The following is a description of a gene set: studied in species Homo sapiens from publication Sengupta S, den Boon JA, Chen IH, Newton MA, Dahl DB, Chen M, Cheng YJ, Westra WH, Chen CJ, Hildesheim A, Sugden B, Ahlquist P (PMID 16912175) Genes whose reduced expression in nasopharyngeal carinoma (NPC) correlated most with the increased expression of EBNA1, a latent gene of Epstein-Barr virus (EBV). Human Gene Set: SENGUPTA_EBNA1_ANTICORRELATED To identify the molecular mechanisms by which EBV-associated epithelial cancers are maintained, we measured the expression of essentially all human genes and all latent EBV genes in a collection of 31 laser-captured, microdissected nasopharyngeal carcinoma (NPC) tissue samples and 10 normal nasopharyngeal tissues. Global gene expression profiles clearly distinguished tumors from normal healthy epithelium. Expression levels of six viral genes (EBNA1, EBNA2, EBNA3A, EBNA3B, LMP1, and LMP2A) were correlated among themselves and strongly inversely correlated with the expression of a large subset of host genes. Among the human genes whose inhibition was most strongly correlated with increased EBV gene expression were multiple MHC class I HLA genes involved in regulating immune response via antigen presentation. The association between EBV gene expression and inhibition of MHC class I HLA expression implies that antigen display is either directly inhibited by EBV, facilitating immune evasion by tumor cells, and/or that tumor cells with inhibited presentation are selected for their ability to sustain higher levels of EBV to take maximum advantage of EBV oncogene-mediated tumor-promoting actions. Our data clearly reflect such tumor promotion, showing that deregulation of key proteins involved in apoptosis (BCL2-related protein A1 and Fas apoptotic inhibitory molecule), cell cycle checkpoints (AKIP, SCYL1, and NIN), and metastasis (matrix metalloproteinase 1) is closely correlated with the levels of EBV gene expression in NPC., and this is the list of marker genes: WBP1L, HPX (hemopexin), MIR4280HG, TNFRSF18, TRAC, KCNK15-AS1, NUTM2F, NAA80, SMPD3, C12orf60, NSUN5P1, EPN2, MIR142, SAP25, PPP1R9B, RPS6KA1, FGD2, RRP1 (NCBI Gene Id 8568), TFEB, NEU3, CRX, UVSSA, HSD17B1, GADD45B, SLC39A3, CCDC74A, NAPSA, ENSG00000263499, SHFL, PTPRE, ZNF710, TRAF3IP3 (TRAF3 interacting protein 3), SLC25A28, MCF2L, ARHGAP27, TECPR1, AURKAIP1 (NCBI Gene Id 54998), NIN, ARL10, CACNA1I, CLEC2D, TTLL3, CFAP221, CES4A, ATP6V0E1, TSPAN33, LENEP, PLK3, PHYKPL, GALNS, ZDHHC14, TP53I13, CYLD, FLJ40288, NLRC5, USP35, EML3, R3HDM2, GDPD5, LIMD1, STARD3, PCNX2, LIMS2, RASAL3, RUBCN, ANXA11, CTLA4, GATA2, SREBF1, DNHD1, FGF11, ABCB9, SIDT2, LINC02481, ACTN2, IDS (NCBI Gene Id 3423), CTNS, PWWP2B, KCNAB2, LRCH4, KIAA0513, ZFYVE28, HLA-A, FCRL1, ITGB3, CCDC32, TMEM102, BORCS6, SIGLEC7, SFXN3, PRX, PARP15, CRYBG2, LINC03000, ANXA9, CISH, B3GALT4, PLEKHM1 (NCBI Gene Id 9842), KCTD17, TMEM225B, H6PD, FAM107A, MAP2K3, SYT11, TNFSF14, USP30-AS1, SPG7, TNFSF13, VAV2, PACSIN1, SYT9, FMNL1, SERPINB9P1, ARHGEF1, CD247, KCNG1, CAMTA2, UBE2O, CCDC141, KCNK7 (potassium two pore domain channel subfamily K member 7), ZFP42, LINC02361, ABHD15, RSPO1, POU6F1, ZBTB17, COTL1, ZC3H10, NHLH1, HLA-F, WDTC1, RAPGEF1, OTULINL, MARCHF2, NSUN5, SLC6A11, SYMPK, SUN2, PLAAT3, ARHGAP4, FCHSD1, FUT5, RASA3, PPARD, EFTUD2, SYDE1, CUTALP, STK10, WDR81, LINC00879, PITX1, NPIPB15, FITM1 (fat storage inducing transmembrane protein 1), LINC00494, LINC02777, FAM13A-AS1, CYFIP2, RHEX, MSRA, PLEKHF1